The following is a description of a gene set: species: Mus musculus Genes predicted to be targets of miRBase v22 microRNA mmu_miR_691 in miRDB v6.0 with MirTarget v4 prediction scores > 80 (high confidence targets). Mouse Gene Set: MIR_691 from publication Chen Y, Wang X (PMID 31504780), and this is the list of marker genes: Stac2 (SH3 and cysteine rich domain 2), Tnrc6b, Dhx40, Inpp4b, Tmcc3, Emilin1, Washc4, Ano3, Phactr3, Ghr, Brdt, Mmaa, Zzef1, Flrt2, Hoxa11, Casp6, Mecp2, Gm11992, Rtn4rl1, R3hdm1, Rbm18, Tgfbr2, Nopchap1, Nlrc5, Btc, Adamts12, Sele, Hdx, Snd1 (staphylococcal nuclease and tudor domain containing 1), Ptgr3, Ubn2, Dmrta1, Bcl2, Kcnd2, Ube2g1, Gria4, Kcnq5, Zc3h12c, Lrrtm1, Ptbp3, Nsd2, Arhgef33, Ttll6, Fezf2, Epb41l1, Tmem229a, Cited2, Ptgdr, Alg9, Sult1b1, Bmp2, Clcf1, Colec11, Zfp397, Casp7, Adck2, Chfr, Asxl2, Foxi2, Nhsl2, Usp12, Trim44, Cdca7l, Spopl, Cep19 (centrosomal protein 19), Vapa, Tmem167, Stk4, Afdn, Pcnx1, Ly6g5b, Ttc28 (tetratricopeptide repeat domain 28), Sox12 (SRY (sex determining region Y)-box 12), Xpc, Tnfsf18, Cacnb2, Pik3ca, Ppp4r3b, Lypd6 (LY6/PLAUR domain containing 6), Fbxl3, Antxr2, Shcbp1l, Pakap, Slain2, Iqsec3, Usp33, Mier2, Pip4p2, Pomgnt1, Lhfpl3, Gata6, Ccny, L3mbtl4, Mfsd1, Actl6a (NCBI Gene Id 99742), Zfp820, Ak3 (adenylate kinase 3), Jakmip3, Cnpy1, Bdnf, Zfp280d, Mob4, Dkk2, Gabpb2, Dmxl2, Ccnt2, Nox4, Ets1, Scarb2, Tmem200a, Plxna4, Tle1, Ino80d, Lrch1, Adarb2, Slc7a11, Sec22b, Cbx6 (NCBI Gene Id 494448), Pkia, Il1rapl2, Xpr1, Slc16a5, Cntn1, Fnbp4, Camkk2, Fam81a, Atp10b, Bcl11b, Slc43a3, Epha5, Mbd1, Zfp553, Cnp (2',3'-cyclic nucleotide 3' phosphodiesterase), Fam204a, Mdh1, Ddi2, Mmp12, Usp13, Eif4a1, Rsrc2, Hoxb2, Cybrd1, Hhip, Atp6v0a1, Eml1, Rab11fip2, Mios, Hoxd8 (NCBI Gene Id 98850), Cdk17, Glt8d1, Cndp1, Mpped1, Ndufa4, Ccdc117, Mtdh, Klhl24, Nme6, Vangl1, Tmx1, Reln, Arid3a, Tmem121, Ythdc2, Hook3, Ube3a, Ncam1, Agfg1, Nefl, Abraxas2, Dlx1, Bach2, Glra2, Creld1, Twist2, Caprin1, Tspan9, Zdhhc21, Tob2, Stox2, Pou3f2, Ormdl2, Cfap43, E130308A19Rik, Tnfsf13b, Slc12a2 (solute carrier family 12, member 2), Cltc, Pcdh17, Nr4a3, Mymk, Micos10, Atp2b1, Eif4e, Bnc1, Slc17a1, Kcnc3, Vnn1, Zfp384, Sp4, Meox2, Ywhab, Col24a1, Gm21992, Txlnb, Cpne1, Npc1, Inpp5d, Gramd2b, Pxn, Ctbp2, Tspan2, Fam53b, Srsf3, Vezt, Cyp2c39, Clrn3, Ablim1, Bicd2, Csmd1, Cdk4, Camsap2, Plxna2, Bltp3a, Zfp281, Mapk8, Phip, Naa30, Cdh5, Braf, Slc38a6, Rbm4, Piezo2, Muc15 (NCBI Gene Id 269328), Vgll3, Tfdp1